The following is a description of a gene set: Nitric oxide (NO) produced by macrophages (MØs) is toxic to both host tissues and invading pathogens and its regulation is therefore essential to suppress host cytotoxicity. MØ arginase 1 (Arg1) inhibits NO production by competing with NO synthases for arginine, the common substrate of NO synthases and arginases. Two signal transduction pathways control Arg1 expression in MØs. First, a MyD88-dependent pathway induces Arg1 in intracellular infections, while a second Stat6-dependent pathway is required for Arg1 expression in alternativelyactivated MØs. We found that mycobacteria-infected MØs produce soluble factors that induce Arg1 in an autocrine-paracrine manner via Stat3. We identify these factors as IL-6, IL-10 and GCSF. We further establish that Arg1 expression is controlled by the MyD88-dependent production of IL-6, IL-10 and G-CSF rather than cell intrinsic MyD88 signaling to Arg1. Our data reveal the MyD88-dependent pathway of Arg1induction following BCG infection requires Stat3 activation and may result in the development of an immunosuppressive niche in granulomas due to the induced Arg1 production in surrounding uninfected MØs species: Homo sapiens Human Gene Set: GSE22935_UNSTIM_VS_12H_MBOVIS_BCG_STIM_MACROPHAGE_DN from publication Qualls JE, Neale G, Smith AM, Koo MS, DeFreitas AA, Zhang H, Kaplan G, Watowich SS, Murray PJ (PMID 20716764) Genes down-regulated in macrophages: untreated versus 12h after M. bovis BCG infection., and this is the list of marker genes: SSBP3, CDK5RAP1, GALNT11, FAHD1, SACM1L, PRXL2C, SEL1L3, SDHD, AKR1B15, STOM, COX4I1, CCNG1, FMNL3, PGRMC1, GGA2, GPCPD1, ACVRL1, SARAF, FANCE, NUF2, SDF2, ULK2 (unc-51 like autophagy activating kinase 2), AATK, NME3, C1QTNF12, IMP4, MRPS21, UMPS, PCYT1A, FASTKD2, ANAPC1, MIA2, NLRX1, C11orf71, SNAP47, RNF26, DHRS3, MRPL41, TTC5, SLC25A3, FAM89B, GABARAP, HRC, TWF2, VPS41, NUP85, CDKN2AIPNL, SLC25A20, HINT3, ZFP36L1, GLE1, DCXR, XPA, RASA1, WRAP53, MRM2, SRPK2, RAD54L, SPTBN1, RPL19, PWP1, NDUFB5, ERCC3, TMEM41A (NCBI Gene Id 90407), C2orf49, IL16, SEPTIN8, SEC61B, CMIP, FBXO33, CBR1, CTNNBIP1, ANGEL2, METTL8, XPO7, SNX3, SLC30A5, CHST14, DIO2, GRAMD4, ZMYM5, BLNK, MIS18A, CTDP1, INPP4A, DNAJC28, LAT2 (NCBI Gene Id 7462), PER1, DYNLRB1 (dynein light chain roadblock-type 1), RPP25L (ribonuclease P/MRP subunit p25 like), ARHGAP6, OTUD6B, NAGA, EI24, ADA, LZTR1, DCTN6, SMARCC1, AURKAIP1, ZNF644, SLC16A7, CTU1, SNX21, DYNLL2 (dynein light chain LC8-type 2), COPS6, SDHA, E2F6, HABP4, DNAJC14, TCEAL8 (NCBI Gene Id 92220), KCNN4, JMJD1C (jumonji domain containing 1C), SEC24D, ELP3, TUBA3C, CD99L2, GPX1, RPL28, NDUFA13, DOCK8, MRPL58, TMEM141, SLC25A26, MMAA, R3HDM1, RANBP10, FASN, ACTR6, CLPX, GPR65, CLK4, VAMP1, SUGP2, ATF7IP, FOXJ2, NUP93, NPM1, STAMBPL1, MRM1, S100A1, EPB41, WBP1, CBX6, POLR2A, VAMP7, ATP6V1D, NFX1, RNF167, ITGB3BP, RPL27A, KLHL9, SLF1, PRR3, STUB1, RDH11, MYLIP, C6orf62, PTS, PINK1, PGM1, HLX, CDC37L1, SREK1IP1, ZFP90, RNF13, ATG2B, NR1H3, TBCEL, CETN3, TMEM33, EXTL3, TMEM214, DPP3, PREB, AKR1B1, SFT2D1, FBXO25, BET1, RPA1, CYRIB, NT5C2, DYNLT1, MYO7A, THRAP3, LAS1L, RPL36, BCAS2, CARMIL1, OXCT1, HADHA, NELFA, PLA2G6, HTR2B, SIAE, CHCHD5, C19orf53, PLPP2, TFEB, PELI2, MRPS12